Given this list of marker genes KLRC2, SLAMF7, SERPINB4, CLNK, RAET1E, STAT5A, UNC13D, SH2D1B, VAMP2, NECTIN2, LYST, LEP, CLEC12B, ARL8B, CORO1A, ULBP3, CD2, IL18RAP, TUBB4B, KLRF2, LGALS9, HLA-B, SH2D1A, HLA-F, KLRC1, KLRK1, CD96, RAET1G, ARRB2, KLRD1, IL18, HCST, CEBPG, ULBP1, CRK, IL12A, RAB27A, RNF19B, AP1G1, CEACAM1, HLA-A, CD160, ULBP2, KLRC4, CADM1, HLA-E, PIK3R1, SLAMF6, VAMP7, KIR3DL1, HLA-G, LAMP1, CLEC2A, CALHM6, IL12B (interleukin 12B), PVR, LILRB1, TIGIT, MICA, TYROBP (transmembrane immune signaling adaptor TYROBP), STAT5B, KLRC3, NCR1, KIF5B, PLEKHM2, IL21, VAV1, TUBB, PIK3R6, KLRC4-KLRK1 (NCBI Gene Id 100528032), LAG3, PTPN6, PRDX1, NKG7, CD226, INPP5D, PIK3CB, NCR3, GZMB, KLRB1, HAVCR2, NECTIN4, SERPINB9, CRTAM, RASGRP4, TGFB1, KIR2DL4, GRB2, FCGR3A, RASGRP1, here is a description of the gene set: species: Homo sapiens The promotion of an immune response by natural killer cells through direct recognition of target cells or through the release of cytokines. Human Gene Set: GOBP_NATURAL_KILLER_CELL_MEDIATED_IMMUNITY